Given this list of marker genes HSDL2, CDK5RAP2, PGAM2, RCAN3, BTG2, DRC1, RRAS2, KLF1, UBALD2, C1orf210, ALDH1L1, IFTAP, APOE, RTKN, MYL11, TRPC4AP, TECPR1, AP3M2, CCR9, MGST2, SLC5A9, TPRG1L, SPINT2, CNTNAP2, ID3, BRDT, DLG3, BST1, SCAMP1, HSD11B1, ITGAE, TCF19, LIPG, PRRT1, IRF9, DDIT4, CDK20, SCML4, LDHB, SLC30A4, RPS6KL1, LMO7, TSC22D3, NCK1, XRCC6, FGGY, CARD10 (NCBI Gene Id 29775), DNAJB9, FNDC1, KLC3, DDC, ARHGAP24, TMEM218, AGPAT3, CYB5A, PMM1, DLST, PTPRO, NEDD4L, SLAMF6, TBXA2R, RAB20, FGFBP1, AUH, TJP3 (tight junction protein 3), PLD3, DEGS1, FBXL12, TRIB2, ELAVL4, GRB7, YPEL5, POLR3GL, ANKRD46, AKAP12, FAAH, GPR34, ATG12, SLC25A35, CD28, ERRFI1, RELB, HMGCS2, MKNK1, IZUMO1R, MYL10, PDLIM5, TMEM115, TMEM230, CRIM1, TAP1, GATA1, EPHX2, RDH10, SNX15, RGL3, MS4A6A, TMEM120B, FAM234B, CD2, PTPN22, BEX1, DEDD2, LRRC61, FBLN2, IL10, CD164, HLA-DOA, IL5RA, ST6GAL1, CLK3 (NCBI Gene Id 1198), KLC4, DOP1B, PRKCQ, SERPINC1, DEGS2, TRAF1, ORMDL3, ARHGEF10L, SMPD1, CYB561, PPARG, LGALS3BP, CD8B, WSB2, HUNK, TXNDC16, DBP, TM6SF1, ITPR2, HPCAL1, SPIB, CDKN2C (cyclin dependent kinase inhibitor 2C), ETS2, CXCR3, STIM1, RAB3IP, LRRC42, ST3GAL1, LMBRD1, KCNH2, RASGRF1, PHYH, PLXDC1, THNSL2, VCF1, DNAAF1 (dynein axonemal assembly factor 1), SIT1, ARRDC4, EPB41L4A, DENND2D, GRAP2 (GRB2 related adaptor protein 2), CBLN1, ADGRE5, AMN, EEFSEC, FAM43A, JCHAIN, FBXW2, PMEPA1, KCTD2, STAMBPL1, ARSI, CAPN3, SPATS2, CLDN4, CANT1, GLMP, CPSF4L, ALDH3B1, TOLLIP, CARHSP1 (NCBI Gene Id 23589), DNAJB4, SFRP2, PDLIM4, GBP6, TSPYL4, SH3BGRL2, DHRS3, TMEM38A (NCBI Gene Id 79041), SCARA3, CTSB, COQ8A, SLC37A2, ST8SIA1, COL4A2, TPST1, STK39, PSAP, TCTA, P4HA2, RORC, SORCS2, ADCY6, ATOH8, SLAMF1, BAIAP3, UBE2H, FBXO6, here is a description of the gene set: Development of T-cells provides a unique opportunity to study cell-fate determination due to the accessability and the well defined stages of developmental stages. In order to understand the genetic programs underlying fetal and adult T‑cell fate specification we subjected highly purified fetal and adult T-cell progenitor populations to a genome‑wide transcriptional analysis. The aim was to identify molecular elements that govern T-cell fate specification as a whole but ultimately to isolate elements that were specific for a given population in a specific developmental window. Human Gene Set: GSE24142_DN2_VS_DN3_THYMOCYTE_FETAL_DN from publication Belyaev NN, Biró J, Athanasakis D, Fernandez-Reyes D, Potocnik AJ (PMID 22581009) studied in species Homo sapiens Genes down-regulated in comparison of fetal DN2 thymocytes versus fetal DN3 thymocytes.